Given this list of marker genes Irgm2, P2rx7, Ccnb1, Parp8, Samd15, Sav1, Calm2, Dazap2, Ccnd3, Map3k12, Atg13, Tex24, Mlst8, Ccnt1, Tcl1b5, Gcn1, Dele1, Nbn, Mtcp1, Bmp4, Iqgap1, Tcl1b4, Bmp7, Irgm1, Tcl1b2, Ccnd1, Igf2, Rictor, Cd40lg, Parp16, Tcl1b1, Ddx3x, Topbp1 (topoisomerase (DNA) II binding protein 1), Ccnd2, Calm1, Acsl1 (NCBI Gene Id 56355), Tgfb1, Gdf2, D1Pas1, Fam20a, Dbf4, Bmp2, Ltf, Stradb, Mob1b, Taok1, Tab1, Tcl1b3, Cks2, Map3k13, Mstn, Mob1a, Cks1b (NCBI Gene Id 99474), Ccdc88a, Cdk5r2, Calm3, Ccnk, Als2, Igf1, Cdk5r1, Pim1, Rad50, Fermt2, Cab39 (NCBI Gene Id 98246), Tcl1, Map2k2, Ccnb1-ps, Map2k1, Cab39l, Adipoq, Etaa1, Igtp (NCBI Gene Id 16145), Mnat1, Strada, Dab2ip, Spry2, Rheb, Parp6, Cks1brt, Lgals9, Ccnt2, Slc27a1, here is a description of the gene set: Mouse Gene Set: GOMF_PROTEIN_SERINE_THREONINE_KINASE_ACTIVATOR_ACTIVITY species: Mus musculus Binds to and increases the activity of a protein serine/threonine kinase.